The following is a description of a gene set: Mouse Gene Set: PANGAS_TUMOR_SUPPRESSION_BY_SMAD1_AND_SMAD5_DN studied in species Mus musculus from publication Pangas SA, Li X, Umans L, Zwijsen A, Huylebroeck D, Gutierrez C, Wang D, Martin JF, Jamin SP, Behringer RR, Robertson EJ, Matzuk MM (PMID 17967875) Genes down-regulated in ovarian tumors from mouse models for the BMP SMAD signaling (gonad specific double knockout of SMAD1 and SMAD5). The transforming growth factor beta (TGFbeta) family has critical roles in the regulation of fertility. In addition, the pathogenesis of some human cancers is attributed to misregulation of TGFbeta function and SMAD2 or SMAD4 mutations. There are limited mouse models for the BMP signaling SMADs (BR-SMADs) 1, 5, and 8 because of embryonic lethality and suspected genetic redundancy. Using tissue-specific ablation in mice, we deleted the BR-SMADs from somatic cells of ovaries and testes. Single conditional knockouts for Smad1 or Smad5 or mice homozygous null for Smad8 are viable and fertile. Female double Smad1 Smad5 and triple Smad1 Smad5 Smad8 conditional knockout mice become infertile and develop metastatic granulosa cell tumors. Male double Smad1 Smad5 conditional knockout mice are fertile but demonstrate metastatic testicular tumor development. Microarray analysis indicated significant alterations in expression of genes related to the TGFbeta pathway, as well as genes involved in infertility and extracellular matrix production. These data strongly implicate the BR-SMADs as part of a critical developmental pathway in ovaries and testis that, when disrupted, leads to malignant transformation., and this is the list of marker genes: Fosl2 (fos-like antigen 2), Knstrn, Rack1, Rgs13, Qsox1, Haus7, Sdf2l1, Gpx7 (glutathione peroxidase 7), Mindy3, Pigo, Olfm1, Lyrm9, Id1, 1810055G02Rik, Dnaja4, Tmed1, Meg3, Elovl2, Tmem39a, Serpina3a, Osgin2, Usp3, Srsf7, Fam161a (NCBI Gene Id 73873), Cert1, Cbs, Rce1, Magea13, Fgfrl1, Drd4, Plekhd1, Arl5b, Anapc7, Spty2d1, Suco, Utp14b, Gm33111, Efcab11, Mapre2, Paip1 (NCBI Gene Id 218693), Srprb, H13, Plekhh1, Yipf4, Chfr, Zswim7, Tnfsf11, Map3k7, Tmem268, Supt16, Igf2r, Comp, Ybx1, Igfbp2, Gabra1, Pcdh18, Scd2, Gpd2, Hspa13, Cyrib, Tmem185b, Lifr, Fdft1 (farnesyl diphosphate farnesyl transferase 1), Cln8, Tmem181c-ps, Hmgb2, Mapk9, Ergic2, Coro7, Acsl3, Lpcat1, Grem1, Gabrb2, Susd4, Ptbp3, Srebf2, Inppl1, 2610507I01Rik, Rimklb, Greb1l, Mfap3l, Tango2, Foxl2os, Tulp2, Rab33a, Ldlr, Fam234a, Zdhhc2, Parl, Wapl, Cntrob, Rsrp1, Arl6ip1, Slc16a1, Mfsd2a, Npr2, Greb1, Hcn1 (hyperpolarization activated cyclic nucleotide gated potassium channel 1), Mapkbp1, Wfs1, Cntf, Hif1a, Dusp9, Bmpr1b, Inhbb, Txk, Lbr, Rian, Lrp8, Rbmx, Mfap3, Max, Lhcgr, Srbd1, Ugcg, Ksr1, Prlr, Slfn3, Gstk1, Dab1, Dnajc10, Tmx1, Atp1a1, Astn1, Nipa2, Cnot6, Lrig2, Icam4, Insyn2b, Mus81, Braf, Ppt2, Elovl6, Tox, Large2, Tom1l1, Ext1, Mrps21, Alms1, Masp1, Bora, Chst8, Arrdc4, Adck5, Nfkb2 (NCBI Gene Id 18034), Rbbp4, Abca7, Lrp11, Nppc, Tmem30a, Hsd17b1, Alg12